The following is a description of a gene set: part of: Synthesis of DNA Switching of origins to a post-replicative state involves the removal of Orc1 from chromatin, CDK-mediated phosphorylation and removal of Cdc6, and the rearrangement and mobilization of Mcm2-7. Reactome Pathway: Switching of origins to a post-replicative state studied in species Homo sapiens, and this is the list of marker genes: MCM4, MCM6, CDC27, ANAPC1, ORC1 (origin recognition complex subunit 1), GMNN, UBB, PSMD12 (proteasome 26S subunit, non-ATPase 12), PSMB5 (NCBI Gene Id 5693), ANAPC2, ORC4, PSMB4, UBE2C, SEM1, PSMC3, FZR1, ORC5, PSMB7, ANAPC10, ANAPC4, RBX1, PSMA1, PSMC6, PSMD2, PSMA7, PSMB2, CDC16, ANAPC16, CDC26, MCM2, SKP2, CCNE1, ANAPC15, PSMA6, CUL1, ORC2, PSMC4, RPS27A, ORC6, UBC, ANAPC5, CDC6, CCNA2 (NCBI Gene Id 890), PSMD14, PSMD8, PSMD13, CCNE2, MCM7, PSMD7, ANAPC7, PSMC1, PSMA2, UBE2D1, UBE2E1, PSMA3, PSMD11, CCNA1, PSMD6, SKP1, CDT1, UBE2S, PSMA5, PSMD1, MCM8, PSMB6, ADRM1, PSMC2, PSMA4, MCM3, CDC23, ANAPC11, PSMB3, PSMB1, ORC3, UBA52, PSMC5, MCM5, PSMD3, CDK2